Given this list of marker genes ADRA1B, GABBR1, ADRA1A, GABBR2, ADRA1D, here is a description of the gene set: studied in species Homo sapiens Human Gene Set: GOBP_NEURON_GLIAL_CELL_SIGNALING Cell-cell signaling that mediates the transfer of information from a neuron to a glial cell. This signaling has been shown to be mediated by various molecules released by different types of neurons, e.g. glutamate, gamma-amino butyric acid (GABA), noradrenaline, acetylcholine, dopamine and adenosine.